Given this list of marker genes Lrwd1, Lemd2, Cdk9, Nipbl, Airn, Spi1, Wbp2, Vcpip1, Mms22l, H1f5, Vcp, Cenpa, Chmp7, Pphln1, Spin1, H2ac4, Rad21, Esco2, Wapl, Plk1 (NCBI Gene Id 18817), Jarid2, Pias4 (protein inhibitor of activated STAT 4), Aplf, Ruvbl2, Setd2, Macroh2a1 (macroH2A.1 histone), Mrnip, Mcm8, Esr1, Ctcfl, Mcm9, Macroh2a2, Parp1, Tasor, Carm1, Brd3, Ezh2, Msh2, Zmynd8, Vrk1 (vaccinia related kinase 1), Daxx, Brd2, Rnf4, Tonsl, Sirt6, Lef1, Mir208b, here is a description of the gene set: Mouse Gene Set: GOBP_PROTEIN_LOCALIZATION_TO_CHROMATIN Any process in which a protein is transported to, or maintained at, a part of a chromosome that is organized into chromatin. studied in species Mus musculus